Given this list of marker genes Ppp1ccb, 1700016B15Rik, Ern2, Rexo5, Hs3st2, Gm23321, 1700069B07Rik, Gm9165, 1700025J12Rik, Prkcb, Igsf6, Acsm5, Abca16, Cdr2, 4933432K03Rik, Mosmo, Gm39078, Tmc7, 4930588G17Rik, 9030407P20Rik, Zp2, Dnah3 (NCBI Gene Id 545996), Crym, Polr3e, Chp2, Otoa, Anks4b, Gm25924 (NCBI Gene Id 115486580), Gm23614, Iqck, Uqcrc2, Tnrc6a, Gm9234, Gm14388, Gm4083, Ndufab1, Gm29977, Acsm3, Dctn5, 2210406H18Rik, Dcun1d3, 4930560O18Rik, Vps35l, Vwa3a, Knop1, Gm20274, E130201H02Rik, Eri2, Mfsd13b, Palb2 (partner and localizer of BRCA2), Abca15, Acsm4, Gm19963, Ears2, Gm16326 (predicted gene 16326), Gm27991, Gm9905 (predicted gene 9905), 4930505K13Rik, Gprc5b, Usp31, Cog7, Gm32916, Gm25217, Gm6905, Gga2, Thumpd1, Ubfd1, Ccp110, Tmc5, Gpr139, B230311B06Rik, Rbbp6, Gm15489, Ldaf1, Eef2k, Pdilt, Gm36736, Plk1, Mettl9, Umod, Cacng3, Gde1, Sdr42e2, Scnn1g, Acsm2, Gm9240 (NCBI Gene Id 676673), Abca14, Gp2, Acsm1, 4930486N12Rik, Gm39079, Scnn1b, 4930413G21Rik, Gm29759, Lyrm1, Pdzd9, Gm26147, here is a description of the gene set: studied in species Mus musculus Mouse Gene Set: chr7F2